The following is a description of a gene set: Any process that modulates the frequency, rate or extent of skeletal muscle cell proliferation. Human Gene Set: GOBP_REGULATION_OF_SKELETAL_MUSCLE_CELL_PROLIFERATION studied in species Homo sapiens, and this is the list of marker genes: MSTN, SIX5, MYOG, AKIRIN1, SELENON, PAXBP1, CFLAR, ANGPT1, SIX1, STAT3, CAV2, ANHX, PPARD, SHH, JAK2, FGF2, EPHB1